The following is a description of a gene set: Human Gene Set: HP_RETINAL_HAMARTOMA A hamartoma (a benign, focal malformation consisting of a disorganized mixture of cells and tissues) of the retina. Retinal hamartoma studied in species Homo sapiens, and this is the list of marker genes: DLST, SDHC, TMEM127, MDH2, SDHA, FH, SLC25A11, TSC1, NF1, CCND1, SDHAF2, SDHD, MAX, SDHB, VHL, NF2, IFNG, AKT1, TSC2 (NCBI Gene Id 7249), RET, KIF1B